Given this list of marker genes ACSL4, ELOVL3, CYP2A6, PLP1, ACSM1, CYP2B6, ACSL6, ACAD9, SLC27A6, MGST3, PTGS1, CYP4A11, GSTM1, CYP4Z1, CYP2C8, ALOX15, ACOT7, ACOT8, MGLL (monoglyceride lipase), PTGR1, CPT1A, GSTA1, PLA2G10, CYP4F12, ACOT2, PNPLA8, GLYATL2, GSTP1, ALOX12B, ELOVL6, CYP2S1, ALOX12, FAAH2, DAGLB, CYP2U1, ACSBG2, CYP1A2, SLC27A4, ACSBG1, GPX1, TMEM135, PLA2G4B, ABCD1, HACL1, FAAH (NCBI Gene Id 2166), PTGS2, GPX4, ACOT4, PLA2G2F, PLA2G4A, ALOX15B, ACOX1, ACSL5, CYP2C9, CYP4A22, PLA2G4C, CPT2, ADTRP, SLC27A2, CYP2A13, ACSF2, CYP4F3, GSTM2, ACOT1, FADS1, ELOVL1, CYP2E1, ALOX5, ACSL1, AIG1, QKI, EHHADH, ABCD2, SLC27A5, CYP1B1, CYP4F11, SCP2, FADS2, SLC27A1, GSTM4 (NCBI Gene Id 82153), ACAA1, CYP3A4, CYP2D6, CYP1A1, HSD17B4, ABHD12, ELOVL2, ACOT9, LTC4S, ABCD3, ASAH2, DAGLA, SLC27A3, AWAT1 (acyl-CoA wax alcohol acyltransferase 1), ACSL3, CYP4F2, ABHD6, CYP2C18, ALOXE3, ELOVL5, CYP2A7, EPHX1, CYP4F8, CYP2C19, CYP2F1, PNPLA3, ACADL, CYP2J2, CTHRC1, here is a description of the gene set: The chemical reactions and pathways involving a long-chain fatty acid. A long-chain fatty acid has an aliphatic tail containing 13 to 22 carbons. Human Gene Set: GOBP_LONG_CHAIN_FATTY_ACID_METABOLIC_PROCESS studied in species Homo sapiens